Given this list of marker genes Hras, Robo1, Rhoa, Dynapl1, Xrcc5, Traf4, Map2k4, Epm2aip1, Adipoq, Epo, Fgd4, Pdgfc, Ccnd2, Agtr1a, Jtb, Erp29, Tlr6, Ppp2r3c, Ntf3, Map2k3, Chi3l1, Syk, Pik3ca, Ripk1, Fbn1, Mapk8ip3, Adra2b, Map3k12, Topors, Src, Btrc, Vldlr, Ect2, Agrn, Igf1, Tcl1, Strada, Pdcd10 (NCBI Gene Id 80414), Adrb2, Rfc3, Snx9, Ralb, Fzd8, Tigar, Arrdc4, Ang, Wnt5a, Map4k2, Ccr7, Lrrk2, Pde5a, Psen1, Cacul1, Angpt1, Ntrk3, Il34, Traf6, Cd4, Epha4, Tpd52l1, Spdye4a (NCBI Gene Id 74673), Hmga2, Chtf8, Tirap (toll-interleukin 1 receptor (TIR) domain-containing adaptor protein), Ube2srt, Ang5, Ip6k2, Dok7, Dab2ip, Arhgef5, Xrcc6, Ins2, Kit, Polg2, Cdk5r1, Mrnip, Map3k11, Cemip, Vegfc, Ccl19, Cdkn1a, Gsk3a, Lilra5, Fzr1, Rassf2, Spdya, Tlr4, Ptk2, D1Pas1, Ang6, Map3k5, Arrdc3, Egfr, Cripto, Cd40, Tnfrsf11a, Abi1, Stox1, Abl1, Irgm1, Ltf, Mmd2, C1galt1c1, Apoa4, Snca, Cdc25b, Dynap, C1qtnf9, Sez6, Reln, Slc11a1, Nek10, Ereg, Cdc14b, Zeb2, Itgb1bp1, Neurl1a, Drd4, Gprc5b, Rad50, Apoa2, Tcim, Tm9sf5, Ube2s, Insr, Hmgn1, Fcer1a, Gas6, Ceacam1 (NCBI Gene Id 26365), Tsacc, Pxn, Pim1, Trib2, Mastl, Cops8, Pdgfb, Apoa1 (apolipoprotein A-I), Nox4, Map2k1, Mmd, Rps3, Il3, Ern1, Lep (NCBI Gene Id 16846), Pih1d1, Ccdc88a, Fgf18, Tnfsf11, Irgm2, Nrxn1, Ang2, Camk1, Ajuba, Nedd9, Il4, Pik3cg, Pak1, Tom1l1, Adra2c, Cd200, Ccny, Ang4, Vangl2, Etaa1, Cdc20, Dscc1, Sesn2, Unc119, Akt1, Npm1, Mapre3, Wnt3a, Spatc1l, Map3k7, Wdr59, Map3k13, Psmd10, Erbb2, Zfp91, Stk11, Rfc2, Cd74 (NCBI Gene Id 16149), Pten, Mre11a, Ccl19-ps4, Asxl2, Stradb, Map3k1, Trib3, Cimap3 (ciliary microtubule associated protein 3), Flt1, Cartpt, Edn3, Syap1, Rap1a, Rfc4, Tnf, Ube2l3, Chtf18, Wdr24, Fzd5 (frizzled class receptor 5), Cab39, Mst1r, Csf1, Edn1, Ppp2ca, Map2k6, F2, Iqgap1, Apoe, Cenpe, Efna1, Ifng, Dab1, Emp2, Ttbk1, Sash1, Adcyap1, Dbi, Ccnd1, Tlr1, Thbs1, Map3k4, Sez6l, Axin1, Trem2, Tab2, Ager, Dvl2, Adam9, Chrna3, Lrp8, Ezh2, Nbn, Mt3, Card10, Ddr2, Psrc1, Adcy8, Tenm1, Gab1, Cd24a, Egf, Grem1, Nrg1, Ccl19-ps3, Mtor, Sirt1 (sirtuin 1), Sez6l2, Ccl19-ps5, Rapgef2, Wnk4, Irak1, Ccl19-ps6, Cib1, Fbxw7, Rfc5, Fzd4, Ern2, Skp1, Tpx2, Ppp1r3g, Prox1, Ppia, Prkag2, Traf2, Tab1, Daxx, Plk1, Ddx3x, Abi2, Higd1a, Ptprc, Pik3r6, Tead1, P2rx7, Clspn, Dusp19, Prkcd, Prlr, Slc1a1, Abi3, Trib1, Dstyk, Pik3r5, Notch2, Map2k2, Bcl10, Pcna, Ube2i, Stil, Agtr1b, Tgfb2, Fgfr1, Pdgfrb, Pibf1, Taok3, Map3k10, Lmo4, Ins1, Agap2, Magi3, Gpr39, Htr2b, Ccl19-ps1, Dlg1, Als2, Cdk5r2, Fgd2, Agt, Bmi1, Ccn1, Chrna7, Kif14, Adam17 (NCBI Gene Id 236174), Stub1, Ccnd3, Map2k7, Pabpn1, Csf1r, Ptpn1, Zfp622, Itgb3, Chaer1, Slc8a2, Adra2a, Jak2, Srcin1, Maged1, Rgcc, Ripk3, Ptk2b, Igtp, Rasgrp1, Rps2, Il1b, Eef1a2, Fgf1, Cass4, Fgf2, Pdgfa, Kitl, Cdk5, here is a description of the gene set: Mouse Gene Set: GOBP_POSITIVE_REGULATION_OF_TRANSFERASE_ACTIVITY Any process that activates or increases the frequency, rate or extent of transferase activity, the catalysis of the transfer of a group, e.g. a methyl group, glycosyl group, acyl group, phosphorus-containing, or other groups, from a donor compound to an acceptor. studied in species Mus musculus